Given this list of marker genes Kcnq1, Pyy, Gpr139, B4galnt2, Tfap2c, Hoxa10, Pou2f3, Vstm2l, Hoxc11, Hoxb7, Ppm1n, Kcnk15, Cbln2, Alx3, Igf2bp1, Prkcz, Hoxb6, Hes2, Nell1, Ajm1, Tmem114, Alx1, Cyp2s1, Lhx5, St8sia3, Cartpt, Dio3, Col15a1, Foxl1, Otop1 (otopetrin 1), Hoxd9, Pdx1, Hnf1b, Hck, Foxn4 (NCBI Gene Id 243222), Gsx2, Drd2, Hoxd12, Pax7, Sigirr, Prdm13, Atp2b2, Scnn1g, Dmrt1, Fezf2, Hoxc8, Jhy, Ripk4, Gfi1, Neurog3, Mixl1, Mesp1, Hoxc13, Nkx2-5, Gata5, Slc7a14, Hoxa11, Six6, Hoxd10, Fstl4, Hoxb5, Atp12a, Crb3, Hoxc12, Sfrp5, Wnt10a, Cdx2, Otp (NCBI Gene Id 18420), Gpr37, Bhlhe23, Htr1a, Tcfl5, Tmem181a, Car10, Grm7, Hoxb9, Cckbr, Hoxb4, C1qtnf4, here is a description of the gene set: DNA methylation is essential for normal development and has been implicated in many pathologies including cancer. Our knowledge about the genome-wide distribution of DNA methylation, how it changes during cellular differentiation and how it relates to histone methylation and other chromatin modifications in mammals remains limited. Here we report the generation and analysis of genome-scale DNA methylation profiles at nucleotide resolution in mammalian cells. Using high-throughput reduced representation bisulphite sequencing and single-molecule-based sequencing, we generated DNA methylation maps covering most CpG islands, and a representative sampling of conserved non-coding elements, transposons and other genomic features, for mouse embryonic stem cells, embryonic-stem-cell-derived and primary neural cells, and eight other primary tissues. Several key findings emerge from the data. First, DNA methylation patterns are better correlated with histone methylation patterns than with the underlying genome sequence context. Second, methylation of CpGs are dynamic epigenetic marks that undergo extensive changes during cellular differentiation, particularly in regulatory regions outside of core promoters. Third, analysis of embryonic-stem-cell-derived and primary cells reveals that 'weak' CpG islands associated with a specific set of developmentally regulated genes undergo aberrant hypermethylation during extended proliferation in vitro, in a pattern reminiscent of that reported in some primary tumours. More generally, the results establish reduced representation bisulphite sequencing as a powerful technology for epigenetic profiling of cell populations relevant to developmental biology, cancer and regenerative medicine. species: Mus musculus Mouse Gene Set: MEISSNER_NPC_HCP_WITH_H3K27ME3 Genes with high-CpG-density promoters (HCP) bearing the H3K27 tri-methylation (H3K27me3) mark in neural precursor cells (NPC). from publication Meissner A, Mikkelsen TS, Gu H, Wernig M, Hanna J, Sivachenko A, Zhang X, Bernstein BE, Nusbaum C, Jaffe DB, Gnirke A, Jaenisch R, Lander ES (PMID 18600261)